Given this list of marker genes AASDH (aminoadipate-semialdehyde dehydrogenase), UBE4B, AMMECR1L, TBXT, C10orf88, NAA15, GOLGA8M, FAM24B, FBXO45, PGBD2, CDK15, SMIM21, PRELID2, LSM8, BBOX1, RFX3, ZNF483, GOLGA8H, ELAVL2, ADGRG2, SLC5A3, SPAG9, SPTY2D1, ZNF454, POU3F1, GOLGA8Q, TWIST2, PDCD6IP, MAPK6, SCP2, CHCHD3, HAS3, ABRAXAS2, TM2D1, HDAC1, SGCB, GOLGA8J, SSBP3, SLC25A36, GOLGA8N, SV2B, DAZAP1, GPBP1L1, GOLGA8T, ANKRD17, RFX7, C8orf58, SLC17A6 (solute carrier family 17 member 6), PTPRN2, TMEM265, AFP, PAX5, TRAPPC6B, FUT9, METTL13, CCNE2, NIM1K, CDK20, ZER1, USP48, SOX6, DIRAS2, SORL1, GOLGA8R, GTF3C4, PDE4D, SNAP25, CCDC28A, ARL13B, here is a description of the gene set: from publication Chen Y, Wang X (PMID 31504780) studied in species Homo sapiens Human Gene Set: MIR1285_5P Genes predicted to be targets of miRBase v22 microRNA hsa-miR-1285-5p in miRDB v6.0 with MirTarget v4 prediction scores > 80 (high confidence targets).